The following is a description of a gene set: Mouse Gene Set: GOBP_LEUKOTRIENE_SIGNALING_PATHWAY A G protein-coupled receptor signaling pathway initiated by leukotriene binding to its receptor on the surface of a target cell, and ending with the regulation of a downstream cellular process. species: Mus musculus, and this is the list of marker genes: Cysltr2, Cysltr1, Ltb4r1, Ltb4r2 (leukotriene B4 receptor 2), Rgs1